Given this list of marker genes Gabrb2, Pou4f1, Prkcg, Slitrk6, Sulf2, Chd7, Unc13b, Nrp1, Isl1, Ark2c, Ret, Vcam1, Ntf5, Sulf1, Ntrk1, Adarb1, Gabrb3, Col25a1, Ednra, Lrig2 (leucine-rich repeats and immunoglobulin-like domains 2), Epha4, Sema3a, Lrig1, Fbxo45, Fgfr3, Serpine2, Edn1, Ece1, Itga4, Gabra5, Unc13a, Lrit3, Nptx1, Npr2, here is a description of the gene set: The process in which a nerve invades a tissue and makes functional synaptic connection within the tissue. species: Mus musculus Mouse Gene Set: GOBP_INNERVATION